The following is a description of a gene set: Table 2S. Genes in MEF, MCV6, MCV8.1 and ES cells by epigenetic mark of their promoter from publication Mikkelsen TS, Hanna J, Zhang X, Ku M, Wernig M, Schorderet P, Bernstein BE, Jaenisch R, Lander ES, Meissner A (PMID 18509334) Mouse Gene Set: MIKKELSEN_IPS_LCP_WITH_H3K4ME3 studied in species Mus musculus Somatic cells can be reprogrammed to a pluripotent state through the ectopic expression of defined transcription factors. Understanding the mechanism and kinetics of this transformation may shed light on the nature of developmental potency and suggest strategies with improved efficiency or safety. Here we report an integrative genomic analysis of reprogramming of mouse fibroblasts and B lymphocytes. Lineage-committed cells show a complex response to the ectopic expression involving induction of genes downstream of individual reprogramming factors. Fully reprogrammed cells show gene expression and epigenetic states that are highly similar to embryonic stem cells. In contrast, stable partially reprogrammed cell lines show reactivation of a distinctive subset of stem-cell-related genes, incomplete repression of lineage-specifying transcription factors, and DNA hypermethylation at pluripotency-related loci. These observations suggest that some cells may become trapped in partially reprogrammed states owing to incomplete repression of transcription factors, and that DNA de-methylation is an inefficient step in the transition to pluripotency. We demonstrate that RNA inhibition of transcription factors can facilitate reprogramming, and that treatment with DNA methyltransferase inhibitors can improve the overall efficiency of the reprogramming process., and this is the list of marker genes: Dlgap3, Podnl1, Itga2b, Adamtsl1, Nanos3, Spi1, Ifi35, Exoc3l, Emp3, C1rl, Cyp4f13, Spon2, Nlrc3, Mip, Tef, Tnip1, Zmym2, Sema4a, Htr3a, Kiss1, Qrfp, Tns2, Ebi3, Tspan32, Dmtn, Pdgfrb, 4631405J19Rik, Selplg, Clstn3, Pstpip1, Zfp57, Gpsm3, Dab2ip, Tnfsf13, Doc2g, Aspg, Tmem248, Igfals, Zfp583, Serpinb9b, Gulo, Laptm5, Angptl2, Acot11, Robo4, Slc29a1, Art1, Ripply1, Snx10, Dapk3, BC028528, Dqx1, Cd68 (CD68 antigen), Kcnn4, Sipa1l3, Scn2b, Ifitm1, Gjd4, Cox7a1, Masp2, Fgf1, Susd2, Nyap1, Oas3, Nr0b2, Hexim2, Myo3b, Arap1, Cysrt1, Spef2, Muc1, Lrcol1 (NCBI Gene Id 381667), Septin1, Neu4, Aldh3b1, Fam25a, Stra6, Mab21l3, Folr1, Cab39, Pde4a, Trex1, Fut2, Gpa33, Mylpf, Slc28a1, 6820408C15Rik, Tango2, Pla2g4f (phospholipase A2, group IVF), Slc5a11, Acsbg2, Art5, Gpr20, Kcnip3, Pipox, Capg, P2rx6, Cd79a, Rorc, Pcolce, G430095P16Rik, Pirt, Klhdc7a, Tnks1bp1, Prrg2, Gpr173, Gck, Trim21, Elovl1, Tapbpl, Notch4, Timp4, Syne4, Phyhd1, Madcam1, Noxo1, Foxr2, Oprk1, Xaf1, Fbxw10, Soat2, Zfand6, Cyp2j6, Ccdc88b, Hipk4, Arhgef11, Fgd4, Ecrg4, Rufy4, F2, Hsd17b14, Vwa5a, Ptprv, Slc39a4, Prr15l, Ccdc120, Nos3, Gpr35, Mrps21, Emilin1, Tbc1d10c, Pinlyp, Zscan2, Cldn19, Oprl1, Hvcn1, Ggnbp1, Glrx, Pklr, Il17rc, Amt, Prx, Lst1, Glmp (NCBI Gene Id 80390), Wars1, Mark2, Ccdc121, Ptpn6, Platr26, Cntnap2, Egfl7, Hacd4, Sytl1, Vwa3a, F5, Hdc, Gstm2, Ston2 (NCBI Gene Id 71022), 1700010I14Rik, Mmrn2, Unc13d, Slc12a8, Aspdh (aspartate dehydrogenase domain containing), Rinl, Rnf151 (NCBI Gene Id 67504), Prickle3, Styxl2, 4930451I11Rik